Given this list of marker genes PARVB, SLC1A5, FHL3, HDC, COX7A1, SPINT2, LAPTM4A, TPSAB1, SEPTIN2, IL18, DUSP1, TMOD1, JUN, CD69, PRDX6, RENBP, ST3GAL4, PEBP1, SQSTM1, TSEN54, KRT1, AKIP1, NHSL3, SLC27A2, SIGLEC8, SIGLEC17P, SNHG8, CTSG, PBX1, GPX4, CDK15, ZBTB20, SLC45A3, COBLL1, HLTF, C7orf50, TMEM44, TCEAL4, VMP1, NMT2, CSF1, EGR1, KIAA1549, RAB38, EPAS1, CATSPER1, LMO4, AREG, LXN, HS6ST1, CPEB4, ALAS1, CAPG, CD33, GBE1, CD59, PMP22, UMPS, TESC (NCBI Gene Id 54997), TPSB2, RGS10, WNK3, ARHGEF6, KIT, CTNNBL1, LGALS3, BATF, COL18A1, BEX4, FXYD5, RGS13, SVOPL, GATA2, ATP6V0A2, NENF, RHOBTB3, AHNAK2, HSP90AB1, BHLHE40, ARMCX3, MPP1, MBOAT7, PTGS2, ANXA11, TUBA1A (NCBI Gene Id 95407), STAP1, MYADM, MAST4, PLIN2, MAGED2, CNIH1, SLC26A2, FOXP1, TMEM220, PSMD1, MACIR, TFG, NFKBIZ, NSMCE1, NTM, ADRB2, NDST2, CYSTM1, NTRK1, BTK, RAC2, CD82, RAB32, LMNA, NDUFAF3, SMYD3, TM6SF1, SMIM3, PTGS1, AKAP5, GLUL, SOX4, CSTPP1, ZNRF1, RAB27B, ALS2, PLGRKT, LYL1, ANXA4, DYNLT5, FAH, AKAP13, GRAP2, FOS, MEIS2, SEC22C, LPCAT2, CD63, RPS6KA5, SDSL, TNFRSF12A, GABPB1, MYB, ACOT7, IDS, RHOH, MITF (NCBI Gene Id 7487), ANXA1, DAD1, ITM2C, STX3, ZBTB32, ANXA7, FOSB, ALOX5AP, FER, MAOB, COX17, TNFRSF4, NSMCE1-DT, VWA5A, BLVRA, STOML2, TMEM176B, ATP6V1F, SYTL3, RARRES1, SLC11A2, SRGN, FCER1A, DUSP6, TSPAN4, P2RY14, LTC4S, ARL2, SERPINB1, LDHB, EGFL7, ASAH1, RHBDD2, PROCR, ALDH1A1, SNX5, IL5RA, TNFRSF21, GATA1, SLC18A2, TNIK, CTTNBP2, DNAJC9, HSD17B12, BACE2, TSC22D1, DYNLL1, ACSL4, CNRIP1, ING2, RALB, IL18R1, TESPA1, LIF, SOCS1, P2RX1, SAMSN1, TMEM233, NDUFA4, DLC1, GCSAML, PPP1R15A, GSTM3 (NCBI Gene Id 2947, glutathione S-transferase mu 3), IL1RL1, VAT1, TMEM154, NFE2L3, CHN2, KREMEN1 (NCBI Gene Id 83999), SCIN, OSBPL8, PKIG, PLAT, RAB34, ARHGAP18, SWAP70, TDRD3, KRT19, ZNF704, NDRG2, TIMP3, GNPTAB, PIK3R6, NFKBIA, STXBP6, STMN1, HS3ST1, MARCHF3, ASRGL1, EIF5, SLC43A3 (solute carrier family 43 member 3), RGS1, GPR65, RNF130, CD44, CTSD, LAX1, HPGD, VIM, GMPR (guanosine monophosphate reductase), ENPP3, HSD17B4, ACER3, DUSP10, CPM, PRNP, RPL36AL, ADAM12, KIF13B, NDFIP2 (Nedd4 family interacting protein 2), DHRS9, RGS2, SLC44A1, CD22, PRKX, PHF20, SERINC3, TUBB6, CPA3, PROS1, H3-3B, GALC, HPGDS, CSF2RB, MLPH, FERMT2, RAB37, PRDX1, MS4A2, CD9, LAT2, KCNH2, AP2M1, CLU, here is a description of the gene set: Human Gene Set: TRAVAGLINI_LUNG_BASOPHIL_MAST_1_CELL from publication Travaglini KJ, Nabhan AN, Penland L, Sinha R, Gillich A, Sit RV, Chang S, Conley SD, Mori Y, Seita J, Berry GJ, Shrager JB, Metzger RJ, Kuo CS, Neff N, Weissman IL, Quake SR, Krasnow MA (PMID 33208946) species: Homo sapiens